Given this list of marker genes Crlf2, Anp32a (NCBI Gene Id 97582), Bckdha, Gskip, Rassf1 (NCBI Gene Id 56289), C1galt1c1, Churc1, B3gat3, Tcf20, Endog, here is a description of the gene set: Genes positively differentially expressed in cell type: NK cell upon treatment with cytokine: G-CSF in mouse lymph nodes in vivo. Cytokines mediate cell-cell communication in the immune system and represent important therapeutic targets. A myriad of studies have highlighted their central role in immune function, yet we lack a global view of the cellular responses of each immune cell type to each cytokine. To address this gap, the authors created the Immune Dictionary, a compendium of single-cell transcriptomic profiles of more than 17 immune cell types in response to each of 86 cytokines (>1,400 cytokine-cell type combinations) in mouse lymph nodes in vivo. A cytokine-centric view of the dictionary revealed that most cytokines induce highly cell-type-specific responses. For example, the inflammatory cytokine interleukin-1β induces distinct gene programmes in almost every cell type. A cell-type-centric view of the dictionary identified more than 66 cytokine-driven cellular polarization states across immune cell types, including previously uncharacterized states such as an interleukin-18-induced polyfunctional natural killer cell state. Mouse Gene Set: CUI_NK_CELL_G_CSF_RESPONSE_UP species: Mus musculus from publication Cui A, Huang T, Li S, Ma A, Pérez JL, Sander C, Keskin DB, Wu CJ, Fraenkel E, Hacohen N (PMID 38057668)